Given this list of marker genes CYP27A1 (cytochrome P450 family 27 subfamily A member 1), LMNA, ACTA2, LIPC, MEF2A, LDLR, PCSK9, ERCC8, APOE, GPIHBP1, LDLRAP1, LRP6, ABCG5, ABCG8, ABCA1, APOB (apolipoprotein B), APOA1, ERCC6, CEP19, here is a description of the gene set: Human Gene Set: HP_PREMATURE_CORONARY_ARTERY_ATHEROSCLEROSIS Reduction of the diameter of the coronary arteries as the result of an accumulation of atheromatous plaques within the walls of the coronary arteries before age of 45. studied in species Homo sapiens Premature coronary artery atherosclerosis